The following is a description of a gene set: To examine the impact of tumors on the immune system, we compared global gene expression profiles of peripheral blood T cells from previously untreated patients with B cell chronic lymphocytic leukemia (CLL) with those from age-matched healthy donors. Although the cells analyzed were not part of the malignant clone, analysis revealed differentially expressed genes, mainly involved in cell differentiation in CD4 cells and defects in cytoskeleton formation, vesicle trafficking, and cytotoxicity in CD8 cells of the CLL patients. In coculture experiments using CLL cells and T cells from healthy allogeneic donors, similar defects developed in both CD4 and CD8 cells. These changes were induced only with direct contact and were not cytokine mediated. Identification of the specific pathways perturbed in the T cells of cancer-bearing patients will allow us to assess steps to repair these defects, which will likely be required to enhance antitumor immunity. Gene expression profiling was performed to determine whether CLL cells induce changes in T cells in patients with CLL. from publication Görgün G, Holderried TA, Zahrieh D, Neuberg D, Gribben JG (PMID 15965501) species: Homo sapiens Genes down-regulated in T cells: CD4 versus CD8. Human Gene Set: GSE8835_CD4_VS_CD8_TCELL_DN, and this is the list of marker genes: PCP2, FBXL13, COL10A1, CALB1, VAT1L, LRMDA, IL36RN, STRN, ADGRB3, AKAP5, TTC9B, HLA-DOA, SULF1, VWA3B, HMGN5, NTM, ALDH1A3, THRSP, OR51E1, BARX2, COLCA1, FIS1, MUC13, MRPL1, F9, MYL1, MRC2, STK36, KHDRBS2, KIAA0825, DCBLD1, PAX5, CCDC92, RHBDD1, AKNA (NCBI Gene Id 80709), GPX8 (glutathione peroxidase 8 (putative)), PTPN1, CLEC4D, FOXA2, FBXL7, TGFA, PWWP4, TTPAL, KATNIP, WDR25, PTPN5, TMT1B, TMED1, HS3ST3B1, MMP2, SMIM23, HAND2, GPR171, HSPB3, DNAJC14, TFAP2A, PDZRN3, IL4, XPOT, LYPD1 (NCBI Gene Id 116372), MIXL1, MYO1A, PRND, C1orf50, CA4, DIO1, CHAC2, CHSY3, TJP1, NDRG1, HTR3B, HIC1, YPEL4, C16orf46, C1orf53, WWTR1, PLPPR5, CARMIL2, MEIS2, DDHD1, TRIR, POPDC2, FUT2, TSTD2, LOXL4, RBP2, RNF10, GPC1, SOX18, THSD7B, LYSMD2, SLC30A7, SYPL2, CES4A, PHF21A (PHD finger protein 21A), SOX30 (NCBI Gene Id 11063), SLC16A5, NEUROG3, CTU1, KRT20, CALB2, SKIDA1, GON4L (NCBI Gene Id 84252), COG8, LAMA2, SLC16A14, KIT, BICDL2, CACNG3, RIPOR3, SPO11, FLRT1, GNGT1, ODAD1, RALGPS1, CD247, OSBPL10, MTMR6, EPHA5, RABEP1, AKR1C3 (aldo-keto reductase family 1 member C3), CA11, PDE5A, SMAP1, FREY1, ZFP42 (NCBI Gene Id 132625), SAP30BP, DACH1, BCL11B, OTP, CYP24A1, PLXNA3, GJB4, KRT8, LMAN1L, ECEL1 (endothelin converting enzyme like 1), SERPINB11 (NCBI Gene Id 89778), SYCP3, CIDEC, PMEL, ZDHHC19, FAM135B, SERTAD4BP, TNFRSF9, SOSTDC1, PIGR, LMOD3 (NCBI Gene Id 56203), TNFRSF10A, GPATCH2, SPMIP7, GJA1, SAXO1, HPS5, TEX11, DLX6, KIF5A, TMEM79, KCNS1, PTPRU, TMEM45B, CMKLR1, COL24A1, TREX2, NPAS3, TMEM38B (transmembrane protein 38B), GPR149, EDN3, SYNPO2, NDUFS4, WDR20, MED12L, EPS8L2, ZNF410, PCDHB12, PPM1H, ITGB4 (NCBI Gene Id 3691), TMIGD1, PRKAB1, GLI1, STARD7, CCL1, C12orf42, GSTA5, TMOD1, SCN2B, WDR31, RCVRN (NCBI Gene Id 5957), NLRP12, BTG4, TMEM127, SLC35G6, USH1C, ADGRL3 (NCBI Gene Id 23284), PCDH15, SGPP2, TMEM9, FLOT1, BRINP2